The following is a description of a gene set: Human Gene Set: GSE3720_LPS_VS_PMA_STIM_VD2_GAMMADELTA_TCELL_DN studied in species Homo sapiens Genes down-regulated in Vd2 gamma delta T cells: LPS versus phorbol myristate acetate and ionomycin. from publication Kress E, Hedges JF, Jutila MA (PMID 16423401) The two major human gd T cell subsets, Vd1 and Vd2, display differences in tissue tropism and agonist responses, but we have little insight into global differences that may exist at the gene expression level. This is due to the small numbers of these cells that can be obtained from healthy donors, which limit comprehensive, comparative gene expression analyses. We established a culture method that expands Vd1 and Vd2 cells from the same PBL preparation to levels sufficient for sorting and microarray analysis. Although the subsets were expanded identically (anti-TCR mAb, plus IL-15), 392 and genes were identified, which were differentially expressed in the two subsets, from two donors, respectively. Approximately genes changed in both subsets following PMA/ionomycin treatment; about 50% of these genes were subset-specific. Both subsets responded to a crude LPS preparation, but only 6% of the responsive genes were the same. The differentially expressed genes were consistent with Vd2 cells being more inflammatory and Vd1 cells having more of a regulatory phenotype. Both subsets expressed transcripts encoding an array of innate and NK cell receptors, supporting the relationship of gd T cells to the innate immune system. Our results show that circulating Vd1 and Vd2 subsets in humans have considerable, inherent differences in gene expression following treatment with non-TCR agonists, supporting unique functional roles for these cells in vivo., and this is the list of marker genes: FHDC1, CCDC116, ECHDC2, PLD4, TRARG1, SLC26A3, CARD10, PPRC1, NEUROG1, CAMKV, LYST, CEP192, BNC2, ADAMTS19, CCDC80, PGAP1, GPR150, OTULIN (NCBI Gene Id 90268), LMAN1, SIDT1 (NCBI Gene Id 54847), AKAP3, CYYR1, SLC6A7, ANAPC11, RIMS3, UTP23, PSPH, ALKBH5, EPS8L1, SMTNL2, GRHL1, MCOLN3, PARM1, IGFBP6, TRIO, SNX7, ADAMDEC1, POU4F3, TGM3, DMRTA2, SLCO1C1, ACOT7, RBFOX1, NLRP5, DRGX, CXCR3, GABRB2, GRM8, SATB1, PRKX, H2AC1, RPS14, PANK4, CCDC81, KLK4, NFU1, PANX1, MMP24, TMCO4, KLHDC8B (kelch domain containing 8B), TADA3, SASH1, ATP8B3, ITSN1, BDNF, SEPTIN11, TM4SF5, NLGN1, GALR2, SHC4, SLC46A2, NKX2-5, MIR448, SOD3, FIGNL2, DGKG, CIITA (NCBI Gene Id 4261), MYH4, EFHC2, KRT2, TMEM25, CCND2, CCN1, RFC1, TM4SF19, LGSN, GAS1, MIGA1, CRYGC, NXPH1, GPR62, AK7, KBTBD11, PHACTR4, SLC27A6, BCL2L1, GFRA2, CBR3, AFAP1L1 (NCBI Gene Id 134265), TMEM237, LY6K, HDAC8, AMPD3, SEPTIN12, CBY3, SOWAHC, HSPB3, KIF11, ADRA2B, KRT80, CNTN3, CDH10, HDX, MAF, VMAC, LAP3, TRIM10, AURKC (aurora kinase C), FUBP3, GPSM3, CHST1, ATL2, CDH19, POC5, CHRNA7, GAS6, ADSL, LY6E, RSPO2, LMAN2L, GBGT1, EPDR1, AIP, CCDC7, ATP6V1B2, GPX1 (NCBI Gene Id 2876), TRPC3, EOMES, PHC2, PDE11A, FKBP9, EIF3M, RPL29, IL10 (interleukin 10), CLDN2, SYNGR2 (synaptogyrin 2), HAPLN4, BRD3, LCE1F, RAMP3, ANO2, SYT12, DNAI3, PHC1, NBL1